Given this list of marker genes ARHGEF18, TGFBR1, CGN, TGFB1, SMURF1, PARD3, TGFBR2, PRKCZ, UBB, PARD6A, FKBP1A, RPS27A, UBC, UBA52, F11R, RHOA, here is a description of the gene set: Reactome Pathway: TGF-beta receptor signaling in EMT (epithelial to mesenchymal transition) studied in species Homo sapiens In normal cells and in the early stages of cancer development, signaling by TGF-beta plays a tumor suppressive role, as SMAD2/3:SMAD4-mediated transcription inhibits cell division by downregulating MYC oncogene transcription and stimulating transcription of CDKN2B tumor suppressor gene. In advanced cancers however, TGF-beta signaling promotes metastasis by stimulating epithelial to mesenchymal transition (EMT). <br>TGFBR1 is recruited to tight junctions by binding PARD6A, a component of tight junctions. After TGF-beta stimulation, activated TGFBR2 binds TGFBR1 at tight junctions, and phosphorylates both TGFBR1 and PARD6A. Phosphorylated PARD6A recruits SMURF1 to tight junctions. SMURF1 is able to ubiquitinate RHOA, a component of tight junctions needed for tight junction maintenance, leading to disassembly of tight junctions, an important step in EMT. part of: Signaling by TGF-beta Receptor Complex